Given this list of marker genes Farp1 (FERM, ARH/RhoGEF and pleckstrin domain protein 1), Sh3bp5, Kazn, Tfap2c, Rapgefl1, Endod1, Tbc1d30, Tiam1, Egr3, Aff1, Rara, Tgif2, Celsr1 (cadherin, EGF LAG seven-pass G-type receptor 1), Scnn1a, Fdft1, Ppif, Nherf1, Ncor2, Blvrb, B4galt1, Unc119, Wfs1, Rps6ka2, Slc16a1, Slc2a1, Cd44, Snx24, Rrp12, Plaat3 (NCBI Gene Id 98147), Mpped2, Sec14l2, Krt19, Med24, P2ry2, Amfr, Itpk1, Scarb1, Dynlt3, Frk, Klf10, Hr, Calcr, Igfbp4, Mybl1, Olfml3, Elf3, Add3, Isg20l2, Mybbp1a, Gja1, Cant1, Bhlhe40, Lrig1, Elovl2, Krt15, Sybu, Elovl5, Nav2, Krt13, Olfm1, Hes1, Celsr2, Npy1r, Reep1, Kcnk15, Adcy9, Greb1, Krt18, Sult2b1, Abhd2, Sema3b, Syt12, Myc, Tpd52l1, Tiparp, Mindy1, Podxl, Muc1, Areg, Kdm4b, Fhl2, Retreg1, Bcl2, Rab31, Pgr, Car12, Slc1a4, Syngr1, Pex11a, Rbbp8, Lad1, Slc27a2, Tob1, Dhrs3, Il17rb, Myof, Asb13, Nadsyn1, Ablim1, Adcy1, Bcl11b, Pdzk1, Tsku, Ovol2, Cyp26b1, Tubb2b, Tjp3, Hspb8, Slc22a5, Pdlim3, Esrp2, Dlc1, Siah2, Slc39a6, Mreg, Slc7a5, Gab2, Cish, Wwc1, Thsd4, Cxcl12, Krt8, Kcnk5, Rasgrp1, Klk10, Slc7a2, Stc2, Opn3, Mapt, Sfn, Fcmr, Ccnd1, Ar, Med13l, Prss23, Ccn5, Cbfa2t3 (NCBI Gene Id 320906), Ptges, Fasn, Foxc1, Sox3, Tpbg, Anxa9, Jak2, Flnb, Inhbb, Bag1, Pmaip1, Msmb (beta-microseminoprotein), Il6st, Arl3, Akap1, Ret (NCBI Gene Id 19713), Nxt1, Slc37a1, Abca3, Xbp1, Rab17, Tmprss3, Slc1a1, Myb, Aldh3b1, Fkbp4, Dhrs2, Tmem164, Rhobtb3, Deptor, Tff3, Gfra1, Ttc39a (NCBI Gene Id 230603), Inpp5f, Ugcg, Igf1r, Aqp3, Slc19a2, Chpt1, Fos, Cldn7 (claudin 7), Rhod, Papss2, Zfp185, Clic3, Fkbp5, Nrip1, Elf1, Abat, Mast4, Eeig1, Slc24a3, Gla, Dhcr7, Svil, Mlph, Tgm2, Calb2, Slc26a2, Klf4, here is a description of the gene set: Mouse genes annotated to HALLMARK_ESTROGEN_RESPONSE_EARLY based on orthology mappings provided by the Alliance Genome Consortium species: Mus musculus Mouse Gene Set: HALLMARK_ESTROGEN_RESPONSE_EARLY from publication Howe DG, Blake JA, Bradford YM, Bult CJ, Calvi BR, Engel SR, Kadin JA, Kaufman TC, Kishore R, Laulederkind SJF, Lewis SE, Moxon SAT, Richardson JE, Smith C (PMID 30224793)